The following is a description of a gene set: species: Homo sapiens Human Gene Set: REACTOME_SEPARATION_OF_SISTER_CHROMATIDS Separation of Sister Chromatids, and this is the list of marker genes: TUBA1B, TUBB6, PSMD12, TUBB4B, UBE2E1, PSMC1, PSMA5, WAPL, UBB, KNTC1, RCC2, STAG2, PPP2R5C, MAPRE1, PSMA1, TUBA4B, STAG1 (NCBI Gene Id 10274), PSMD11, NDC80, RANBP2, AHCTF1, SKA1, NDEL1, TAOK1, CKAP5, UBE2S, PPP2CB, SPDL1, PSMD7, KIF2B, XPO1, UBC, CDC27, PSMD6, NSL1, SEM1, PTTG1, BUB1B, DSN1, PAFAH1B1, CENPQ, CENPM, TUBB2A, CLASP2, TUBA8, ZWINT, DYNLL2, PPP2R1A, PSMC4, TUBA3D, PSMD14, CENPN, PSMD13, NUP133, TUBB4A (NCBI Gene Id 1864), SEC13, NUP107, CDC26, PDS5B (PDS5 cohesin associated factor B), TUBB1, HDAC8 (histone deacetylase 8), CENPO, ITGB3BP, RANGAP1, ANAPC11, NUP98 (nucleoporin 98 and 96 precursor), ZWILCH, CENPL, PMF1, NDE1, CDCA5, PPP2R5A, PSMD8, PSMD1, ANAPC4, NUP85, BIRC5, TUBB3, SPC24, MAD2L1, RPS27A, PSMA6, CENPP, ANAPC16, ANAPC10, PPP2R5E, DYNC1I2, DYNC1H1, BUB1, PPP2R5B, AURKB, PSMC6, ZW10, CENPA, ESPL1, CENPT, ADRM1, PDS5A, TUBA3C, PSMB6, KIF2C, PSMA3, TUBAL3, BUB3, NUP160, CENPH, PSMC5, NUDC, CDC23, B9D2, TUBB8, PSMD3, DYNLL1, CDC16, PSMB7, KNL1, INCENP, CENPS, PSMA7, PPP2R5D (NCBI Gene Id 5528), SGO1, CENPC, PPP1CC, PSMB2, DYNC1LI1, PPP2CA, DYNC1LI2, PSMB1, SMC1A, PSMB4, NUP37, PLK1, NUP43, CDC20, KIF18A, ANAPC2 (NCBI Gene Id 29882), CDCA8, RPS27, CENPI, NUF2, TUBA3E, TUBA1A, PSMB3, SKA2, SGO2, RAD21, CLASP1, SMC3, PSMA2, ANAPC1, UBA52 (NCBI Gene Id 7311), TUBA4A, KIF2A, ANAPC5, ANAPC7, PSMC3, TUBA1C, CENPF, CENPK, DYNC1I1, ANAPC15, PSMD2, SPC25, PSMB5, PPP2R1B, MAD1L1, CENPU, PSMA4, TUBB8B, PSMC2, CENPE, CLIP1, UBE2C, MIS12, ERCC6L, TUBB2B, SEH1L (SEH1 like nucleoporin), UBE2D1